Given this list of marker genes PIK3CG, MLST8, PARP2, MTOR, PIK3R5, AKT2, PIK3C2A, PIK3R4, TSC1, PDK1, PIK3CD, IKBKG, AKT1, PIK3R2, RICTOR, STK11, PIK3C2G, TSC2, RPTOR, PIK3CB, PARP1, PIK3R3, PIK3R6, PIK3R1, AKT3, PIK3CA, MAPKAP1, PARP3, PHLPP1, ATM, GSK3B, FOXO1, SIRT1, PIK3C2B, here is a description of the gene set: AKT signaling and ARTD family members studied in species Homo sapiens Human Gene Set: WP_AKT_SIGNALING_AND_ARTD_FAMILY_MEMBERS